The following is a description of a gene set: Genes predicted to be targets of miRBase v22 microRNA hsa-miR-642a-3p, hsa-miR-642b-3p in miRDB v6.0 with MirTarget v4 prediction scores > 80 (high confidence targets). Human Gene Set: MIR642A_3P_MIR642B_3P species: Homo sapiens from publication Chen Y, Wang X (PMID 31504780), and this is the list of marker genes: PROX1, TMEM116, PPM1A, NCOR1, ARL6, MEIS2, BEX4, SPRY1, PTPRG, VPS26B, CCDC144NL, GAB1, CENPE, MARCHF6, ANO5, RHOT1, DIP2C, PRIM1, ADORA2B, DHX32, FRK, TMTC2, CHST1, GOLGA4, POU2AF2, LEMD3, CEP57, POFUT1, PABPN1, SCARB2, NCOA7 (NCBI Gene Id 135112), PDCD10, EXOG, TPH2, MYO5A, SERPINE1, SPESP1, SH3RF1, NNAT, FAM13C, MTMR7, CBL, SYNCRIP, NDUFA4, LRIG3, BCL2L2-PABPN1, USP25, TMED4, LRRFIP1 (LRR binding FLII interacting protein 1), ZNF449, JPH1 (junctophilin 1), PGR, GTF3C4 (general transcription factor IIIC subunit 4), TSPAN12, EML6, IFNA8, MMP10, CPLX2, ZNF559-ZNF177, HNRNPU, KRT75, NCAPG2, SYT17 (synaptotagmin 17), SCN3A, RNGTT, BASP1, IQGAP1, VKORC1L1, SLX4IP (NCBI Gene Id 140682), SMOC2, RSBN1L, C5orf15, RAD51B (RAD51 paralog B), AMHR2, AFF4, PCDH12, AGO4, TEAD1, GTPBP10, NIT2, VGLL3, SEPTIN3, PCDH18, DCN, ILDR2, SRGAP1, AP1S3 (NCBI Gene Id 130340), TXNDC15, ETNPPL, NIPA1, IFNG, ZNF350, SERP1, QPCT, ATG12, GCLM, TPPP, PPP2R2A, FLT1, SOD2, DENND2D, YLPM1, YRDC, EDDM3A, ATP8B1, RAB28 (RAB28, member RAS oncogene family), PMS1, CDH22, WAPL, ZNF177, SFT2D1, MYOF, ARSB, SEPTIN7, RNF11, COMMD2, BCOR, SLC4A8, ZEB1, C6orf89, PPP2R1A (NCBI Gene Id 5518), SLC35F2, BEND4, CEP63 (NCBI Gene Id 80254), SLITRK4, PTPN5, BAZ1A, SKP1, USP27X, SPRED1, TP53BP1, CSMD1, COPS2, GPC6, CXCL3, CD200R1, CACNA1G